Given this list of marker genes FGG, FGB, ITGB3, FGA, ITGA2B, here is a description of the gene set: Prolonged/excessive menses and bleeding at irregular intervals. species: Homo sapiens Human Gene Set: HP_MENOMETRORRHAGIA Menometrorrhagia